Given this list of marker genes RPL23A, RPL27, SRP19, RPL22L1, SEC61A2, RPL36AL, RPS4X, RPS3, RPS7, RPL22, RPS3A, RPL18, RPL7A, RPL18A, RPS16, RPL39L, SSR1, RPL21, SRP72, RPL13, RPL3, UBA52, RPL36, RPS27, FAU, SEC11C, RPL14, RPL8, SRP68, DDOST, SSR2, RPS6, RPS27A, RPS4Y2, RPS9, RPL4, RPS11, SEC11A, RPS18, RPS15, SSR3, RPS5, SPCS1, RPL34, RPL35, RPLP0, RPLP2, RPL17, RPS10, SPCS2, RPLP1, SRP9, RPS15A, RPS14, SRP14, RPN2, RPL36A, RPL23, RPS8, RPSA, RPL19, RPL12, RPL9, RPL35A, SRPRB, SEC61G, TRAM1, RPS2, RPL30, RPS27L, RPL31, RPL28, RPL15, RPL38, RPL26L1, RPS19, RPL37, RPN1, RPS24, RPS28, RPS13, RPL13A, SEC61A1, RPL10A, RPS25, RPS21, RPL26, RPS26 (NCBI Gene Id 6231), SPCS3, RPL3L, RPL5, RPS12, RPL32, RPL6, RPL11 (ribosomal protein L11), SRP54, RPL41, SEC61B, RPS20, RPL39, SSR4, RPL29, RPL24, RPS4Y1, RPL10, RPL7, RPS23, RPS29, SRPRA, RPL10L, RPS17, RPL27A, RPL37A, here is a description of the gene set: studied in species Homo sapiens SRP-dependent cotranslational protein targeting to membrane Human Gene Set: REACTOME_SRP_DEPENDENT_COTRANSLATIONAL_PROTEIN_TARGETING_TO_MEMBRANE